Given this list of marker genes Tcf7, Tcf7l2, Ctnnb1, Mapk14, Myrip (myosin VIIA and Rab interacting protein), Mitf, Hint1, Sytl2, Sin3a, Tcf7l1, here is a description of the gene set: part of: MITF-M-regulated melanocyte development studied in species Mus musculus electronically inferred by orthology from the curated human pathway Reactome Pathway: MITF-M-dependent gene expression This event has been computationally inferred from an event that has been demonstrated in another species.<p>The inference is based on the homology mapping from PANTHER. Briefly, reactions for which all involved PhysicalEntities (in input, output and catalyst) have a mapped orthologue/paralogue (for complexes at least 75% of components must have a mapping) are inferred to the other species.